Given this list of marker genes DVL1, ALG8, RERE, KCNH5, ANXA11, GLI3, MEF2C, VRK1, SGCG, OCA2, GPC3, KCNN3, INSR, KCNQ1, PRX, TGDS, SDHD, UNC13A, MYMX, WRAP53, MED13L, SOD1, HEXB, COL7A1, PEX26, AKT1, PABPN1, EHMT1, POMGNT1, PROP1, IGHMBP2, CRPPA, ENG, PON2, NTRK1, PEX14, ASAH1, ROR2, TERT, BAP1, DAO, SLC37A4, HMBS, WDR35, BCR, UHRF1, CLIC2 (NCBI Gene Id 1193), PLAGL1, TMEM237, INTU, MMP1, TSPYL1, RAB3GAP2, KAT6B (lysine acetyltransferase 6B), COG7, SYNGAP1, ADNP, NOP56, ERLIN2, WNT5A, B9D1, WDPCP, SNIP1, BAZ1B, ELP1, NKX2-5, TMEM107, KIF1A, P4HA2, SAA1, CCDC47, GSN, PEX6, IYD, CPSF3 (cleavage and polyadenylation specific factor 3), PERP, GNE, LMNB2, SLC25A21, AIP, MT-TE, ADPRS, CDC42BPB, RETREG1, KCNH1 (NCBI Gene Id 8656), GNS, SQSTM1 (sequestosome 1), IDUA, HDAC9, VPS13B, DLK1, GPR101 (NCBI Gene Id 83550), GRIK2, NRXN1, KCNQ1OT1, TBX15, IRF6, REV3L, OPTN, MAPK1, OFD1, TBX22, POLR1B, LARGE1, TCOF1, BMP4, TMEM270, FAM149B1, SMARCA4, MEG3, TSHB, CAVIN1, ARSB, B9D2, PIGS, AFF3, GJB6, SUFU, MED25, TARDBP (TAR DNA binding protein), VPS37D, PON3, GTF2IRD2, BSCL2, RAB34, SLC26A4, ATXN2, FXR1, PFN1 (profilin 1), PRKAR1A (NCBI Gene Id 5573), VAC14, ATP6V1B2, KLLN, ATRX, FLNA, THRA, CLTRN, ZFP57, DYNC2I1, SCN9A, EXOSC3, PLCB4, KIAA0753, ATP13A2, SDHC, GAA, TRANK1, ZBTB24, SMN2, HNRNPA1, IDS, PRR12, CNTNAP2, CHD6, PRPH, GNAI3, NF2, VWA1, LMNA, EDNRA, FOS, DOK7, PANK2 (pantothenate kinase 2), FASLG, RTL1, BUD23, SPTBN1, AP1S3, POU1F1, ERBB4, RPGRIP1L, CHCHD10, ANG, COG1, TAF1, DYNC2H1, TRIP11, SLC6A19, TG, FZD2, PEX10, MFN2, COL11A1, SLC5A5 (solute carrier family 5 member 5), HNRNPK, DYNC2I2, ZMPSTE24, KIAA0586, NCF1, FREM2, UBA1 (ubiquitin like modifier activating enzyme 1), PRKAG2, AGA, MBD5, GUSB, CAV1, FRAS1, MGAT2, MMACHC, TCTN3, MAN2B1 (NCBI Gene Id 4125), ECM1, SYT2, UBQLN2, TAF4, DHX30, KY, IFT140, B2M, TMEM67, MYH3, POP1, AMN, PMP22, GPC4, SETBP1, TRPV3, FIG4, USF3 (upstream transcription factor family member 3), CSNK2A1, DHCR7, TXNDC15, RNF125, SLC25A46, PLXND1, RBM10, FRG1 (FSHD region gene 1), CFAP410, LMBRD1, POLG, EIF4H, NEK9, NFIX, PDGFB, OTX2, POMK, POMT1, PI4KA, CUL4B, TCTN1, CCNF, SNX14, DNMT3B, RUNX2, KCNK9 (potassium two pore domain channel subfamily K member 9), TBK1, WNK1, FAM20C, SNRPN, SMAD4, PIK3CA, PEX1, AMPD2, NXN, HRAS, SDHB, HS2ST1, EXOSC8, PSMB8, MDM4, ELN, EXOSC9, PPARGC1A, GLB1, NKX2-1, HYMAI, DCTN1, ACVRL1, PQBP1 (NCBI Gene Id 5974), SCN1A, ACTB, SRPX2, VPS13A, GLE1, EGR2, AIFM1, TRAF3IP2, TOPORS, ECEL1, TELO2, MTPAP, MCTP2, PRUNE1 (NCBI Gene Id 91961), SERPING1, CCDC22, SLC46A1, GMPPB, LGI3, PEX16, TMEM231, IPO8, SBF2, ALG6, FKRP, SH3TC2, TAF15, SLC52A2, ARID1A, GTF2IRD1, HLA-DRB1, ATP1A2 (NCBI Gene Id 93186), KCNJ11, TBL2, GRIP1, ZNF699, LMNB1, PDE6D, PEX2, NEFH, LIMK1, IL36RN, GJB2, CSNK2B, C2CD3, ALS2, H4C5, PTDSS1, COL2A1, PDE11A, SLC52A3, ZFX (zinc finger protein X-linked), TOE1, TSHR, SLC25A24, SMO, LHX3, TMEM216, FTO (NCBI Gene Id 79068), KRT5 (keratin 5), SNRPB, IL6ST (interleukin 6 cytokine family signal transducer), SEC23B, TPO, MATR3, DNAJC30, MEGF10, HELLS, UBE3A, PKP1, LAMA2, SOX5, HESX1, KRT6A, MORC2, TRIM37, AGPAT2, FOXG1, RAB3GAP1, PIGW, COL11A2, CEP290, PON1, DUOXA2, PEX5, GIPC1, RBBP8, GDF2, VPS33A, POMT2, SMARCE1, PIGB, IFT80, PRRX1, VAPB, AGTPBP1, NEU1, RFC2, RSPO2, SLC35C1, VCP, FBXO28, PEX3, CEP120, FIBP, LHX4, KRT14, CASP10, RPS6KA3, PTH1R, XPNPEP2, CRKL, MID1, TCTN2, LIMS2, PEX11B, PRRT2, CUBN, KDM5C, LIFR, TRAF7, GTF2I, GRHL3, DNM1, NEK1, CHRNG, PEX19 (peroxisomal biogenesis factor 19), CACNA1A, KMT2D, RILPL1, TBCK, SOX9, FOXE1, NFASC, NEFL, TRMU, ALX3, PAX8, CHMP2B, PIK3C2A, METTL27, ATP11A, NOTCH2NLC, MBTPS2, INPP5E, PTEN, WNT10A, POU4F1, CSPP1, KCNMA1, MKS1, FAM111A, CPLANE1, STX1A, FBXO11, PEX12, FKBP6, RIPK4, SREBF1, SMN1, NDUFS4, SET, DVL3, MPZ, ABCC8, MUSK, LRP12, PEX13, CC2D2A, GNPTAB, EDN1, PTPN22, MYMK, RMND1, RNU4-2, TUBB4A, ALG3, PPARG (peroxisome proliferator activated receptor gamma), HLA-B, FDX2, AFF4, SCNM1, SLC35B2, POLR1D, RALGAPA1, POLR1C, BTK, RMRP, SLC39A4, MAN2C1, KIF7, ADGRG1, SMARCB1, FUS, CDCA7, FUCA1, IGF2, POGZ, DDX59, TREM2, CDKN1C, CLIP2, DUOX2, GLT8D1, RPGRIP1, TBCD, SPTLC1, FAS, here is a description of the gene set: studied in species Homo sapiens Any abnormality of the tongue. Abnormality of the tongue Human Gene Set: HP_ABNORMALITY_OF_THE_TONGUE